The following is a description of a gene set: studied in species Homo sapiens Human Gene Set: GOBP_ESTABLISHMENT_OF_LYMPHOCYTE_POLARITY The directed orientation of lymphocyte signaling molecules and associated membrane rafts towards a chemokine gradient or a contact point with an appropriate activating cell., and this is the list of marker genes: CRTAM, RIPOR2, SNX27, CCR7, DOCK2, CCL19, DOCK8, ABL2, CCL21, SCRIB, ABL1, FLOT2, TRAF3IP2, CYP26B1, MYH9, GSN